The following is a description of a gene set: species: Homo sapiens from publication Travaglini KJ, Nabhan AN, Penland L, Sinha R, Gillich A, Sit RV, Chang S, Conley SD, Mori Y, Seita J, Berry GJ, Shrager JB, Metzger RJ, Kuo CS, Neff N, Weissman IL, Quake SR, Krasnow MA (PMID 33208946) Human Gene Set: TRAVAGLINI_LUNG_CAPILLARY_INTERMEDIATE_1_CELL, and this is the list of marker genes: TINAGL1, ZDHHC14, MXD4, TIMP3, BAIAP2 (BAR/IMD domain containing adaptor protein 2), MBOAT2 (NCBI Gene Id 129642), B3GALNT1, FNBP1L, CYP3A5, HLA-DRB1, CMTM3, PLIN2, SERPINB6, HLA-DQA1, STC1, PREX1, DENND2B, PCDH1, FHL1, TNFRSF1A, IFNGR1, TMEM204, S100A4, TMEM51, ANXA3, DNAJC1, SERPINB1, ACE, CD83, NEDD9 (NCBI Gene Id 4739), TUBA1A, EMP2, PHLDB1, GPX1, RCSD1, TYMP, JAM3, SPARC, MYO6, ITGA1, WASF2, VIPR1, RAPGEF5, CNN3, FENDRR (NCBI Gene Id 400550), TSC22D3, IL32, NTN4, ICAM1, TMEM100, HLA-DQB1, SAMD9L, RPN1, FRY, HLA-B, PDLIM1, TBX3, CD82 (NCBI Gene Id 8052), RSRP1, ATP2B4, EDN2, ADGRL2, TBXAS1 (thromboxane A synthase 1), HOPX, RGCC, HLA-DRB5, CX3CL1, PLAU, ISG20, EDNRB, RTN4, FZD4, PRKCE, SLC14A1, SYNGR2, CCND3, CSF1, RASAL2, CDH5, TSPAN15, PAPSS2, ZNF331 (zinc finger protein 331), FKBP5, SLCO4A1, RNASET2, UBC, STX11, PLEKHG1, GPX3, IBA57, ITGA5, SOSTDC1, ESAM, CHST2, IL15RA, SLCO3A1, IL7R, F2RL3, TSPAN12, SGK1, NUAK2, PDGFB, CD74, PRX, MYADM, NCALD (neurocalcin delta), TNIP1, SH2D3C (NCBI Gene Id 10044), TBX2, KIAA1217, ADGRF5, KLF7, PLAGL1, STXBP6, PPP3CC, ANXA1, FAXDC2, FMNL2, GALNT18, EMCN, DOCK9, VAT1, TGFBR3, SERPINE1 (serpin family E member 1), HSPB8, DISP1, WFDC1, CA2, ITGA3, MYLK, ZFP36L1, CDKN2B, PIK3IP1, CD14, EDIL3 (NCBI Gene Id 10085), ACVRL1, FOXF1, IL1RL1, S100A3, PHLDA1, KCNQ1OT1, RRAS, AFF3, ICAM2, HECW2, IRF1, DNAJB1, PALD1, AQP1, EXPH5, EFNB1, CA4, MTSS1, PCDH12, HPGD, PPP1R15A, MEF2A, DLGAP4